The following is a description of a gene set: Human Gene Set: GSE27786_LSK_VS_NKCELL_UP studied in species Homo sapiens Each fraction of mouse hematopoietic cells was purified by cell sorting from bone marrow of 8-week-old C57BL/6 mice, and its gene expression was analyzed. from publication Konuma T, Nakamura S, Miyagi S, Negishi M, Chiba T, Oguro H, Yuan J, Mochizuki-Kashio M, Ichikawa H, Miyoshi H, Vidal M, Iwama A (PMID 21540074) Genes up-regulated in comparison of LSK versus NK cells., and this is the list of marker genes: KIFAP3, KLHDC1, TSC22D1, CDC16, WDPCP, PRDX4, LANCL2, NUDT12, PIGN, PUS1, QTRT2, RNF122, TSPAN6, MRPL38, TPI1, GADD45GIP1, LIPT1, SAPCD1, RABGGTB, FBXL6, TFAM, HMGXB3, PAICS, SGSM1, PARD6G, GPATCH1, PAQR8, MYO1D, PRUNE1, VCP, IFT74, SIRT4, PHTF1, PEX13, CA12, AFP, FMO2, TCAF1, MFGE8, MATK, TCP1, BCAP29, METTL13, SUV39H1 (SUV39H1 histone lysine methyltransferase), RRP9, MAT1A, SRRT, VSIG10, PHPT1, TXN2, C6orf132, TMEM42, F2RL3, ACOT2, TRIQK, PDXP, TIPIN, PLXNA3, THBS4, HOXA10, FBXO3 (F-box protein 3), DDX56, BCHE (NCBI Gene Id 590), SSX2IP, TRIB2, RCOR3, ABHD4, RSPH3, YTHDF2, HYAL2, WDR83OS, KTI12, WDR19, ITGA7, ATP5F1A, THUMPD1, FAM234B, SRPK1, NISCH (nischarin), TRIM33, ACSL3, RAD54L, RUVBL2, IL11RA, INAFM1, RNMT, AKAP9, H2AX, TRIM13, PDSS2, CENPV, ST14, NTRK2, ZNF319, RCC1L, HOXA5, E2F7, NR2C1, NUDCD2, STK26, MLKL, PHF10, WDR6, PCBP4 (NCBI Gene Id 57060), GNA15, CLNS1A, IRF2BP1, CRISP2, PCK2, WNT10B, GLOD4, ARL3, TMEM177, POLR1C, SETD4, NSUN5, TBC1D4, MTHFD1, TMEM106C (transmembrane protein 106C), C10orf88 (chromosome 10 open reading frame 88), GABRR1, TTLL12, CHORDC1, ALKBH1, UROC1, RPUSD1, FGGY, TUBA4A, CPQ, UBE2T, PAX6, SLC25A23, EARS2, AAMDC, RHEBL1, TAP2, CSRNP2, NDE1, TBC1D31, CCDC120, BMP1, CHRNB1, TDP1, PPRC1, INMT, SLF2, TOPBP1, NUDT6, UQCC6, MACROH2A2, CENPH, TMEM252, FIRRE, RLIG1, TCEAL9 (transcription elongation factor A like 9), ZNF48, FLOT1, BOD1, CASP7, PEX5, TK1, C8orf82, GLE1, TGFA, CCNF, RFC1, NIFK, B3GLCT, HAGHL, PSPC1, COQ4, MLEC, STARD10, TNFAIP8L1, NCAPG2, CCDC34, AJUBA, FLYWCH2, BLZF1, CDC23, COPS3, FOCAD, EHBP1, CAMKK1, RAMP1, CDCA7L, RDH11, RETSAT, NOP56, DTWD1, IPO11, DNAJB4, NAA10, SHLD2, ADGRD1, LDB1, BASP1, IPO4, GART, DDX27 (NCBI Gene Id 55661)